The following is a description of a gene set: species: Homo sapiens Genes having at least one occurence of the motif TCCCCAC in their 3' untranslated region. The motif represents putative target (that is, seed match) of human mature miRNA hsa-miR-491 (v7.1 miRBase). Human Gene Set: TCCCCAC_MIR491, and this is the list of marker genes: GPD1, IGF2BP1, DNAJB5, CFAP263, MEIS2, PUM1, MAP1A, RNF40, ATP2A1, GIPC1, SYNGAP1, CSRP1, SCAF1, MAPKAP1, IL1RAPL1, DMRT2, AGPAT1, SMARCD1, TRPV4 (transient receptor potential cation channel subfamily V member 4), CDHR5, PDGFRA, ARL4D (ADP ribosylation factor like GTPase 4D), VWA1, KHDRBS1, GDAP2, C2CD2L, HPS1, APH1A, SEMA4G, STC1, DMPK, KAT7, AKAP1, MBD6, ATXN2L, TLN1, CHD4, APPBP2, HOXC11, SEMA6D, ZBTB4, SEH1L, ITPKA, TRIM33, MPV17, ZNF644, N4BP3, TCF7, AGFG1, B4GALT5, ZC3H7B, TAF10 (TATA-box binding protein associated factor 10), PATZ1, ESYT3, TRIOBP, PLPPR4, MN1, MOCS1, NFIB, CHD3